The following is a description of a gene set: Mouse Gene Set: GOBP_T_HELPER_CELL_LINEAGE_COMMITMENT species: Mus musculus The process in which a CD4-positive, alpha-beta T cell becomes committed to becoming a T-helper cell, a CD4-positive, alpha-beta T cell specialized to promote various immunological processes., and this is the list of marker genes: Ly9, Stat6, Otud5, Brd4, Tbx21, Lgals1, Slamf6, Il4, Tgfb1, Il6ra, Loxl3 (NCBI Gene Id 16950, lysyl oxidase-like 3), Irf4, Opa1, Tnfsf18, Spn, Il6, Mtor, Ep300, Il23a, Cd69 (NCBI Gene Id 76049), Batf, Brd2, Stat3 (NCBI Gene Id 68733)